The following is a description of a gene set: Any process that results in a change in state or activity of a cell or an organism (in terms of movement, secretion, enzyme production, gene expression, etc.) as a result of an axon injury stimulus. Mouse Gene Set: GOBP_RESPONSE_TO_AXON_INJURY studied in species Mus musculus, and this is the list of marker genes: Rangap1, Trem2, Ptprf, Ctnna1, Ptn, Gap43, Gip, Epo, Cdk1, Erbb2 (NCBI Gene Id 13866), Tnc, Kremen1, Lrig2, Pcsk1, Lamb2, Lrp1, Cspg5, Sod1, Nefh, Dpysl3, Omg, Rgma (repulsive guidance molecule family member A), Dhfr, Rtn4rl1, Klf4, Bex1, Apoe, Folr1 (NCBI Gene Id 14275), Fgf2 (NCBI Gene Id 14173), Stk24, Kcnb1, Dag1, Bnip3, Tnr, Apoa4, Plcg2, Morn4, Enpp1, Sarm1, Braf, Ptprs, Tyrobp, Jak2, Inpp5f (NCBI Gene Id 79372), Ndp, Apoa1, Xylt1, Cntf (ciliary neurotrophic factor), Nefl, Matn2, Drd2, Tspo, P2rx4, Ntrk1, Pum2, Pten, Grn, Mapk8ip3, Nppc, Map1b, Mmp2, Axl, Gipr, Nrep, Mag, Cers2, Kcnk2, Fgfr3, Ndel1, Rtca, Scarf1, Rtn4r, Lyn, Bax, Nrg1 (neuregulin 1), Map2k1, Slc1a1, Txn2, Flrt3, P2ry12, Map2k2, Sod2, Igf1r, Jun, Apod, Max, Bcl2, Ntrk3, Epha4, Matn4, Rtn4rl2, Naip2, D130043K22Rik, Shh, Fkbp1b, Chl1, Adam17, Neo1, Flna, Mtr